The following is a description of a gene set: Mouse Gene Set: REACTOME_INTERFERON_SIGNALING species: Mus musculus Interferon Signaling, and this is the list of marker genes: Ifna6 (NCBI Gene Id 384100), Tubal3, Nck1, Dhx9, Nedd4, Prkra, Ifna15, Faap24, Becn1, Rnasel, Tubb6, Ifna5, Mx2, Jak2, Ptpn1, Sumo1 (small ubiquitin-like modifier 1), Oasl1, Chuk, Mapt, Pias1, Npm1, Socs1, Ptpn6, Sphk1, Cdk1, Hspa1b, Rps27a, Tuba1a, Ppp2cb, Faap20 (Fanconi anemia core complex associated protein 20), Ppp2r1a, Ifna1, Adar, Camk2a, Fanca, Ubb, Ifna16, Ilf2, Ifna14, Tubb2b, Tuba1b, Ubc, Ptpn2, Mapk1, Fkbp5, Mavs, Dus2, Raf1, Tuba1c, Tuba3a, Rigi, Tubb4a, Uba7, Ifngr2, Prkcd (protein kinase C, delta), Ifnab, Ifi44l, Hspa8, Abce1, Irf9 (interferon regulatory factor 9), Uba52rt, Hspa2, Dnajc3, Socs3, Fancc (Fanconi anemia, complementation group C), Eif4g1, Cenpx, Camk2d, Cenps, Ifna2, Tubb1, Ifnb1 (NCBI Gene Id 15977), Fancg, Ifna4, Isg15, Ifna13, Ikbkb, Ppm1b, Hspa1l, Ikbkg, Ppp2r5a, Eif4g2, Ifna11, Ilf3, Stat3, Eif4e3, Tuba3b, Ppp2r1b, Tubb2a, Trp53, Snca, Ifngr1, Ifna7, Ifnar1, Ybx1, Flnb, Arih1, Tubb3, Fance, Faap100, Stat2, Eif4e2, Ifit1bl2, Eif4e, Ifi44, Mapk3, Ifna9, Ube2l6, Eif4g3, Ifna12, Ube2n, Trim25 (tripartite motif-containing 25), Camk2b, Eif4a3, Fancm, Fancb (NCBI Gene Id 237211), Ptpn11, Usp18, Pde12, Eif2ak2, Eif4a2, Fancl, Tuba8, Ifng, Ppp2ca, Ube2e1, Tuba4a, Uba52, Hspa1a, Tubb4b, Tarbp2 (TARBP2, RISC loading complex RNA binding subunit), Plcg1, Ifnar2, Irf3, Camk2g, Fancf (NCBI Gene Id 330538), Kpnb1, Kpna1, Map2k6, Tyk2, Eif4a1 (NCBI Gene Id 13681)